The following is a description of a gene set: from publication Mata-Haro V, Cekic C, Martin M, Chilton PM, Casella CR, Mitchell TC (PMID 17569868) studied in species Homo sapiens Human Gene Set: GSE7768_OVA_ALONE_VS_OVA_WITH_MPL_IMMUNIZED_MOUSE_WHOLE_SPLEEN_6H_DN An unresolved issue in immunology is the extent to which inflammatory effects are needed for robust T cell responses. In this study, mice were immunized by iv injection using either high toxicity lipopolysaccharide (LPS) or low toxicity monophosphoryl lipid A (MPL) as adjuvant. Six hours after iv immunization, whole spleens were harvested and gene expression was measured in unfractionated splenic populations of cells. The analysis indicated that the low toxicity adjuvanticity of MPL was associated with TLR4-mediated signaling that was biased to the TRIF branch of TLR4, while LPS generated balanced MyD88 and TRIF-associated outcomes. Genes down-regulated in spleens from mice immunized with ova peptides alone versus those immunized with monophosphoryl lipid A as adjuvant., and this is the list of marker genes: HINFP, ARHGAP25, NLRC5, CD38, ISG15, TMEM68, PIK3AP1, SVBP, SCARF1, GSAP, ACSL1 (acyl-CoA synthetase long chain family member 1), LGALS8, TLK2, EEIG2, MCM10, ATP10A, NPEPPS, SAMHD1, HMCN2, PSMB9, CRLF3, FAS, GTPBP2, CD2AP, CREM, ISOC1, ELF1, TMEM67, CASP1, PIK3R6, USP25, ALAS1, ZC3HAV1, SP110, SAMD9L, RAB29, CD274, SFXN2, GNA15, KEAP1, ATOH1, CCDC42, PTGES, IL7, MLKL, PDCD10, PSME4, GCH1, DCLRE1C, SMPDL3B, FEZ2, GOLGA3, XAF1 (NCBI Gene Id 54739), CERS6, PLA1A, CYCS, MAP2K4, TPST1, RNF14, NAMPT, ZC2HC1A, ZCWPW2, SLC25A28, PELI1, PHC2, TMEM170B, NEUROD4, NSMAF, POMP, ALDH1B1, SNAP29, HPS3 (NCBI Gene Id 85393), CCR9, PCGF5, EHD4, MT-CO1, MYD88 (MYD88 innate immune signal transduction adaptor), SAV1, APOOL, ARHGAP31 (Rho GTPase activating protein 31), CCNYL1, IL23R, OSM, MIER3, CTRL, IKZF1, MAPKAPK2, CUL2, USP12, TMOD3, XKR8 (NCBI Gene Id 86422), TPBG, KAT2B, RAP2C, POU5F1, DRAM2, AIM2, TRIOBP, HAP1, CASP4, TLR8, PSMA5, BBX, TDRD7 (NCBI Gene Id 23424), AFTPH, CAB39L, TMEM171, TOX4, FAM53C, CCNJ, VPS37B, ST18, MARCHF5, WHAMM, TRAF5 (NCBI Gene Id 7188), ABLIM2, OASL, ZC3H7A, CXCL10, COX18, ELOA, ARF4, SLAMF7, PTTG1 (PTTG1 regulator of sister chromatid separation, securin), H3-3B, AZI2, STAT3, BRWD3, TMEM219, MOB3B, FMR1, SRGAP2, PPA1, IFIH1, ITGB1BP2, NSD3, CDH1, MXD1, ACOT9, MMP14, NUB1 (negative regulator of ubiquitin like proteins 1), ASB13 (NCBI Gene Id 79754), NOD1, BRAF, DBNL, P4HA1, INTS9, MORC3, CFB, PLEKHA2 (pleckstrin homology domain containing A2, NCBI Gene Id 651347), TLR3, FMNL2, DCP2, SMG7, UPP1, IRF2, PNP, AIDA, RBM43, TUT7, PNPT1, CMKLR1, GPD2, INO80